Given this list of marker genes Etnppl, Myod1, Eif4ebp1, Nr3c1 (nuclear receptor subfamily 3, group C, member 1), Il17a, Smyd3, Ddit4, Sgk1, Crh, Serpinf1, Gjb2, Cyp1b1, Tbx2, Zfp764l1, Ifnb1, Edn1, Agtr1b, Adcyap1 (NCBI Gene Id 11516), Ass1, Scnn1a, Foxo3, Eif4e, Ube2l3, Zfp764, Bmi1, Akr1c18, Zfp36l1, Anxa1, Egfr, Sstr4, Trim63, Klf9, Sstr3, Stc1, Zfp747l1 (NCBI Gene Id 78921), Pck1 (phosphoenolpyruvate carboxykinase 1, cytosolic), Nr3c2, Gstp1, Aifm1, Ugt1a6a, Scnn1g, Mettl21c, Mstn, Zfp36, mt-Nd3, Ccl2, Fam107a, Gsk3a, Atp5f1a, Sstr5, Scnn1b (NCBI Gene Id 20277), Tgfb1, Abcb1a, Rest, Aqp1, Gdnf, Axin2, Fech, Ugt1a6b, Casp9 (caspase 9), Star, Pck2, Mir21a, Agtr2, Gper1, Hmgcs2, Mir155, Foxo1, Fbxo32, Zfp36l2, Jak2, Sstr2, Agtr1a, Npas4, Ugt1a1, Hnrnpu, Zfp747 (NCBI Gene Id 269997), Bmp4, Gsk3b, Rps6kb1, Ace, here is a description of the gene set: studied in species Mus musculus Mouse Gene Set: GOBP_CELLULAR_RESPONSE_TO_CORTICOSTEROID_STIMULUS Any process that results in a change in state or activity of a cell (in terms of movement, secretion, enzyme production, gene expression, etc.) as a result of a corticosteroid hormone stimulus. A corticosteroid is a steroid hormone that is produced in the adrenal cortex. Corticosteroids are involved in a wide range of physiologic systems such as stress response, immune response and regulation of inflammation, carbohydrate metabolism, protein catabolism, blood electrolyte levels, and behavior. They include glucocorticoids and mineralocorticoids.